The following is a description of a gene set: Genes predicted to be targets of miRBase v22 microRNA mmu_miR_3070_3p in miRDB v6.0 with MirTarget v4 prediction scores > 80 (high confidence targets). species: Mus musculus Mouse Gene Set: MIR_3070_3P from publication Chen Y, Wang X (PMID 31504780), and this is the list of marker genes: Hnrnpa0, Tcte1, Brpf3, Skint4, Lipg, Pim1, Klhdc1, Kcnd2, Kcmf1, Tmtc4, Crocc2, Nppa (natriuretic peptide type A), Spata1, Dnmt3a, Dcc, Arid3b, Ift122, Als2cl, Scfd1, Gpr37, Iqca1, Rtn4, Zbtb18, Fez2 (fasciculation and elongation protein zeta 2), Kcnj3, Rtl4, Acap2, Ppip5k1, Poc5, Ppt1, Syncrip, Reck, Map3k1, Btg1, Nrf1, Smap2, Usp24, Adamts4, Brwd3, Rfwd3, Lin54, Sorbs2, Tbc1d20, Slc35d3, Stab2, Oprl1, Htr1f, Mfsd14a, Rims2